The following is a description of a gene set: The process whose specific outcome is the progression of a cardiac ventricle over time, from its formation to the mature structure. A cardiac ventricle receives blood from a cardiac atrium and pumps it out of the heart. Mouse Gene Set: GOBP_CARDIAC_VENTRICLE_DEVELOPMENT studied in species Mus musculus, and this is the list of marker genes: Ctnnb1, Zmpste24 (zinc metallopeptidase, STE24), Mir17, Scn5a, Tgfbr3, Kcnk2, Chd7, Wnt11, Sall4, Myh6, Ptk7, Tnni3, Eva1a, Gsk3a, Myh7, Bmpr1a, Bmp10, Pkp2 (plakophilin 2), Fzd1 (NCBI Gene Id 14362), Mybpc3, Notch1, Dll4, Lmo4, Ccn1, Foxc1, Mesp1, Ccm2l, Mir20a, Ltbp1, Mir19a, Fgf9, Greb1l, Bmp4, Fgfrl1, Mir92-1, Ahr, Ptcd2, Trip11, Matr3, Ube4b, Heg1, Hand1, Hectd1, Sox4, Hes1, Tgfbr2, Xirp2, Rxra, Hand2os1, Isl1, Pcdha9, Rnls, Sav1, Sfrp2 (NCBI Gene Id 99743), Cplane1, Col11a1, Lrp6, Npy2r, Myl3, Smad6, Myl2, Stra6, Npy5r, Pitx2, Gja5, Slit2, Sufu, Nog, Egln1, Smarcd3, Hoxa13, Vangl2 (NCBI Gene Id 93840), Cited2, Fgfr2, Heyl, Robo2, Nfatc1, Tbx3 (T-box 3), Epo (erythropoietin), Tnnc1, Mir18, Cxcr4, Hey2, Nprl3, Cntrl, Sox11, Foxh1, Mdm4, Nos3, Tgfb1, Sall1, Epor, Klk1b1, Fkbp1a, Nrg1, Zfpm1, Id2, Jag1, Cpe, Ryr2, Tgfb2, Slit3, Pde2a, Tmem65, Adamts19, Rbpj, Eng, Prdm1, Rbm15, Sema3c, Hif1a, Dnm2 (dynamin 2), Aplnr, Ednra, Mef2c, Acvr1, Dctn5, Smad7, Frs2, Robo1, Pou4f1, Ly6e, Zfpm2, Hand2, Tnni1 (NCBI Gene Id 98425), Nkx2-5, Naglu, Lrp2, Gata4, Foxf1, Foxc2 (forkhead box C2), Tbx20, Hey1, Grhl2, Prox1, Myocd, Luzp1, Tbx5, Smad4, Tgfbr1, Bmpr2 (NCBI Gene Id 98751), Ppp1r13l, Mir19b-1, Wnt5a, Nsd2, Pax8, Smarca4, Ap2b1, Tpm1, Mdm2, Dand5, Dsp, Fzd2, Gata3, Tnnt2, Med1